Given this list of marker genes SMAD1, MIR92A1, ITGA5, CLIC3, MIR30B, VEGFA (NCBI Gene Id 7422), TJP1 (NCBI Gene Id 7082), DLL1, DSG2, PKM, JMJD8, TGM2, MIR126, GHSR, IL10, FUT1, HMGB1, MIR1-1, S100A1, BMPER, FGF1, MIR125A, FGF2, JAK1, KLF4, GHRL, JCAD, PDPK1, TNN, MIR31, MIR1224, here is a description of the gene set: Human Gene Set: GOBP_POSITIVE_REGULATION_OF_SPROUTING_ANGIOGENESIS studied in species Homo sapiens Any process that activates or increases the frequency, rate or extent of sprouting angiogenesis.